The following is a description of a gene set: Primary focal segmental glomerulosclerosis (FSGS) species: Homo sapiens Human Gene Set: WP_PRIMARY_FOCAL_SEGMENTAL_GLOMERULOSCLEROSIS_FSGS, and this is the list of marker genes: UTRN, CR1, KIRREL2, MYO1E, NPHS2, PLCE1, CD80, ACTN4, PARVA (parvin alpha), SCARB2, ITGA3, ILK, CLDN1, PODXL, KIRREL3, LAMB2, PLAUR, TLN1, DAG1, JAG1, COL4A4 (NCBI Gene Id 1286), CD2AP, TRPC6, YWHAQ, VCL, LRP5, LRP6, SYNPO, FYN, CTNNB1, CDKN1B, IRF6, CDH2, CTSL, ITGAV (integrin subunit alpha V), SMARCAL1, ITGB4, LMX1B, VIM, COL4A5, LIMS1, KRT8, PTPRO, CDKN1A, AGRN, PTK2, FAT1, NPHS1, NCK1, CDKN1C, TLR4, VTN, ITGB3, TGFB1, DKK1 (dickkopf WNT signaling pathway inhibitor 1), DNM1, INF2, WT1, PCNA, PLCG1, MME, LAMA5, CD151, NOTCH1, COL4A3, AKT1, PAX2, MYH9, ITGB1, MKI67, CAMK2B, WNT1